The following is a description of a gene set: Human Gene Set: KONG_E2F3_TARGETS from publication Kong LJ, Chang JT, Bild AH, Nevins JR (PMID 16909124) Functions encoded by single genes in lower organisms are often represented by multiple related genes in the mammalian genome. An example is the retinoblastoma and E2F families of proteins that regulate transcription during the cell cycle. Analysis of gene function using germline mutations is often confounded by overlapping function resulting in compensation. Indeed, in cells deleted of the E2F1 or E2F3 genes, there is an increase in the expression of the other family member. To avoid complications of compensatory effects, we have used small-interfering RNAs that target individual E2F proteins to generate a temporary loss of E2F function. We find that both E2F1 and E2F3 are required for cells to enter the S phase from a quiescent state, whereas only E2F3 is necessary for the S phase in growing cells. We also find that the acute loss of E2F3 activity affects the expression of genes encoding DNA replication and mitotic activities, whereas loss of E2F1 affects a limited number of genes that are distinct from those regulated by E2F3. We conclude that the long-term loss of E2F activity does lead to compensation by other family members and that the analysis of acute loss of function reveals specific and distinct roles for these proteins. species: Mus musculus Genes up-regulated in MEF cells (embryonic fibroblasts) at 16 hr after serum stimulation and knockdown of E2F3 by RNAi., and this is the list of marker genes: FBXO45, NASP, UBE2T (NCBI Gene Id 29089), CENPK, SPDL1, RBBP8, CDCA5, FEN1, KIF11, MKI67 (NCBI Gene Id 4288), PSIP1, H4C6, RAD54L, PBK, DLGAP5, MCM3, SNORD22, RBL1, USP1, CBX2, IQGAP3, LMNB1, TAF1D, BUB1B, ERCC6L, CENPQ, TAL2, FIGNL1, MYB, RACGAP1, KIF20A, RAD51AP1, HMGB2, IGF2BP1, RPRD1B, PRC1, NCAPG, KIF2C, CCNB1, FAM111A (FAM111 trypsin like peptidase A), AURKA, PCLAF, RPL3, DCK, DNA2, CCNE1, H4C9, CDCA3, EZH2, HJURP, GP1BA, CENPF, TPX2, RAD51, NCAPG2, TYMS, SMC2, MELK, CDC6, NR1D1, CHAF1B, SRSF7, E2F3, NCAPD2, RPL12, HMMR, NCAPH, H2AX, CCNA2, H2AC8, GAS5, HLX, SYCE2, MAPK8, TK1, H4C1, BUB1, NUSAP1, MED1, BRCA1, SPC25, CCNF, UBE2C, PSORS1C2, NUF2, TOP2A, NUP50, DEPDC1, TACC3, PLK1, CDC20, CDC7, INCENP, CENPH, ASF1B, SKP2, SHCBP1, F13A1, PRIM1